Given this list of marker genes POLR1C, COL9A3, IFT172, BBS4, FREM1, PAX3, DVL1, BUB3, PPP1R15B, DNA2, SLC45A1, NECAP1, NOVA2, SMOC1, DHX30 (NCBI Gene Id 22907), C12orf57, POLR1B, TAF4, CEP295, CUL4B (cullin 4B), KIF11, H4C9, SPRED1, FHL1, NPHP1, TMEM237, RNU4ATAC, PUS7, FGFR2, SPECC1L, BBS7, H4C5, HRAS, GP1BB, NEK9, RNF135, RIN2, RPS19, KCNC2 (potassium voltage-gated channel subfamily C member 2), NALCN, CLTC, UNC80, BBS5, GMNN, RPS28, YWHAE, ARID1B, SLF2, DOCK3, SATB1, GABBR2, SON, POGZ, SLC19A3, GALNT2, TBX1, MAP3K7, RASA2, PKDCC, MSL3, GLE1, H3-3A, SHOC2, FOXG1, POLR1A, TNRC6B, TRIM32, USP9X, POLR3A, DALRD3, PSMD12, EIF5A, OTUD6B, SNRPB, BCORL1, EEF1A2, CRTAP, STAC3, ATP7A, KREMEN1, FGFR3, AUTS2, LETM1, CENPE, ATP1A3, SKI, AMPD2, SPART, CAMTA1, B3GAT3, CKAP2L, BBS2, RECQL4, SPIN4, MYMK, DPH2, DDX59, MYH3, SETD2, CEP19, SETD1A (NCBI Gene Id 9739), CREBBP (CREB binding protein), BRD4, HS6ST2, ACTL6B, TCOF1, ZNF148, ATP6V1E1, DPH1, SMPD4, BCL11A, TSPEAR, DHDDS, PTEN, FGD1, ABAT, FOXP1, COL11A2, GABRA5, SLC29A3, HEATR3, NAA20, CYFIP2 (cytoplasmic FMR1 interacting protein 2), PPP2R5D (protein phosphatase 2 regulatory subunit B'delta), CEP57, MAP2K1, HNRNPK, NF1, BRPF1, SEC24D, BICRA, YY1, MED12L, CEP152, NELFA, MYMX, FLNA, RBBP8, DOK7, RNU4-2, AMMECR1, SLC25A24, ZSWIM6, NFIX, PACS2, JMJD1C, SZT2, CLCN4, DSE, KPTN, DYNC2LI1, GAD1, TGFB3, BBS1, PACS1, ARL6, CHD1, KAT6B, SMAD2, ACTB, ADNP, SLC2A10, MN1, FBXO11, WAC, DHODH, SLC9A7, TBR1, KMT2E, DPM1, SDCCAG8, ODC1 (ornithine decarboxylase 1), NONO, SOS1, CHD7, DNM1, ZNF462, WBP4, FILIP1, NECTIN1, YWHAG, CASK (calcium/calmodulin dependent serine protein kinase), LMNA, KDM5B, UMPS, APC2, PEX3, RAF1, SYNGAP1, SETBP1, PRPS1, CFAP418, ROR2, AP4E1, DHCR7, TFE3, SLC1A2, MYOD1, TRIP13, RAI1, KIFBP, AKT1, PPP3CA, ALDH1A2, KIF7, FLI1, SCLT1, SOS2, SCN1A, COL5A1, DPP9, MTOR, GORAB, EP300, PDGFRB, ARID2, NUP85, CSGALNACT1, FZR1, IL6ST, FBXO28, UBE3A (NCBI Gene Id 7337), ARHGEF2, ATP6V1B2, NSD1, BGN, BMPR1A, ANKRD11, NOTCH2, SIN3A, SCN3A, CCDC22, MKKS, GATA4, TSR2, RLIM, GNPNAT1, BBIP1 (NCBI Gene Id 92482), DYNC1H1, KDM1A, MID1, COMT, KRAS, BUB1B, ZMYM2, SOX5, RIT1, WWOX, EBF3, RRAGC, TTC8, DNAJC21, NAA10, SMC1A, KCNH1, TUBB3, ACSL4, GRIN2D, PCNT, NTRK2, CWC27, TRIO, HECTD4, SLC32A1, EFTUD2, UFD1, SCAPER, ZMIZ1, GABRA2, DBR1, EFEMP1 (NCBI Gene Id 399564), RRAS, CDK10, PGM2L1, BRAF, TASP1, EED, UBA5, CTBP1, MAP2K2, IGBP1, ZEB2, CENPT, SET (NCBI Gene Id 6418), PTPN11, GSC, TRMT10A, COG1 (component of oligomeric golgi complex 1), SMARCA2, KDM5A, WNT5A, SCN4A, IDH1, CELF2, NXN, HNRNPC, HERC1, EDEM3, IFT27 (intraflagellar transport 27), SH3PXD2B, WDPCP, GJA1, NFIB, TRAIP, EFNB1, CAMK2A, FGFR1, SIAH1, TGFB2, MED12, AHDC1, ESCO2, MAPK1, ALG2, NRAS, HUWE1 (HECT, UBA and WWE domain containing E3 ubiquitin protein ligase 1, NCBI Gene Id 54789), CEP290, RPS6KA3, AGO1 (NCBI Gene Id 26523), FLCN, PARS2, CHRNA7 (NCBI Gene Id 1139), TNNI2, SCN8A, OTUD5, P4HB, CLCN3 (NCBI Gene Id 133073), NR4A2, LDHD, ALDH6A1, PTCH1, RAPSN, CHST14, OSGEP, PLOD1, CTCF, CDK19, ARVCF, MKS1, MAPRE2, NEXMIF, RDH11, ATP1A2, ACTG1, OTUD7A, WASHC5, DVL3, LTBP1, PLK4, CPLX1, CCDC115, TWIST2, COL11A1, CNKSR2, ZFX, AP3B2, KAT5, CDC42BPB, PIGG, COLEC11, ZBTB20, IL11RA, NSD2, DPYSL5 (dihydropyrimidinase like 5), ZMPSTE24, GABRG2, LZTFL1, NOTCH3, HCN1, FGF12, DHCR24, FBXO31, IFT74, LRP2, MGAT2, FAM20C, SEMA5A, CHD8, POLR1D, BBS12, PURA, PPP1CB, SF3B4, BUB1, BBS10, GPC4, CHST3, SATB2, BBS9, CBL, KMT2A, HBA2, RAB3GAP2, DPF2, MAN1B1, RYR1, FGF3, KDM6A, NSRP1, FZD2, DYRK1A, BPTF, KCNN3, SEC24C, DMXL2, EBP, SETD5, RAP1B, SUZ12, KCNA2, MAF, RRAS2, CDH2, ASPH, ADAMTS2, SPEN, SLC38A3, OFD1, KCNE5, TMEM147, LZTR1 (NCBI Gene Id 8216), GLI3, HNRNPH1, PITX1, UBR7, TAF1, VPS13B, MASP1, SLC39A13, SPRED2, BAP1, CACNA1A, ORC6, TRAK1 (trafficking kinesin protein 1), LRP4, CNTNAP2, FIBP, THUMPD1, TFAP2B, PRRX1, AFG2B, EFEMP2, TWIST1, KCNB1, ZIC1, PHOX2B, RREB1 (NCBI Gene Id 6239), ARCN1, PYCR2, ASXL3, VPS35L, DPYD, SETD1B (SET domain containing 1B, histone lysine methyltransferase), CDC42, HIRA, JARID2, AFF4, SLC26A2, CDH11, PAFAH1B1, SC5D, TMCO1, KMT2D, PIK3CA, PCGF2, TGFBR1, MPDZ, APC, ATP6V0A2 (NCBI Gene Id 7854), CACNA1B, PRR12, GABRB2, MRAS, CTNND2, BMP2, SPOP, EZH2, FBN1, SKIC3, RERE, ATRIP, CHRNG, ATR, NUS1, HBA1, PYCR1, SYNJ1, SUPT16H, SNAP29, PPP2R1A, MED25, ATP6V1A, MVK, ABCA5, SLC13A5, COLEC10, KCNMA1 (NCBI Gene Id 3778), CACNA2D1, AARS1, FBXL4, KIF15, SCNM1, GPC3, here is a description of the gene set: studied in species Homo sapiens Downslanted palpebral fissures The palpebral fissure inclination is more than two standard deviations below the mean. Human Gene Set: HP_DOWNSLANTED_PALPEBRAL_FISSURES